Given this list of marker genes Fzd4, Lrp5, Col4a1, Ndp, Lama1, Cyp1b1, here is a description of the gene set: species: Mus musculus Mouse Gene Set: GOBP_RETINAL_BLOOD_VESSEL_MORPHOGENESIS The process whose specific outcome is the progression of a blood vessel of the retina over time, from its formation to the mature structure.